The following is a description of a gene set: from publication Gao S, Yan L, Wang R, Li J, Yong J, Zhou X, Wei Y, Wu X, Wang X, Fan X, Yan J, Zhi X, Gao Y, Guo H, Jin X, Wang W, Mao Y, Wang F, Wen L, Fu W, Ge H, Qiao J, Tang F (PMID 29802404) Human Gene Set: GAO_STOMACH_24W_C1_PROCRPOS_MULTIPOTENT_PROGENITOR species: Homo sapiens, and this is the list of marker genes: DTX3L, UBE2S, GJC2, FAM229A, TRAF4, CDC45, H2AX, SNX7, PLK4, POMT2, GPT2, SLC25A38, MAML2, PLD1, ANKRD37, ZFAND1, MTA1, PWWP2B, ZNF354C, CASP3, SCARF2, SLX4IP, ZNF571, RPE, PPIH, PITPNM2, KIAA1586, LRRC57, KLHL11, DNAL4 (dynein axonemal light chain 4), LGSN, MTOR, C2CD2, ZFP41, ZNF143, INTS15, NUDT8, CENPQ, SGK1, DDX31